Given this list of marker genes CLOCK, ATR, DELEC1, NPAS2, CRY1, CSNK1E, CHEK1, WDR5, NONO, CRY2, BHLHE40, NR1D1, PER1, TIMELESS, PER2, BMAL1, here is a description of the gene set: from publication Schaefer CF, Anthony K, Krupa S, Buchoff J, Day M, Hannay T, Buetow KH (PMID 18832364) Circadian rhythm pathway species: Homo sapiens Human Gene Set: PID_CIRCADIAN_PATHWAY